The following is a description of a gene set: Genes predicted to be targets of miRBase v22 microRNA hsa-miR-1321 in miRDB v6.0 with MirTarget v4 prediction scores > 80 (high confidence targets). Human Gene Set: MIR1321 species: Homo sapiens from publication Chen Y, Wang X (PMID 31504780), and this is the list of marker genes: NISCH, SOX13, HTT, HECTD4, ZNF444, C20orf96, FZD1, LRRTM1, SH3PXD2B, GATAD2B, PIANP, TP53INP1, REG1B, SSH1, NFAM1, PAX1, LSM8, ABL2, NEMP2, NFIX, PHF8, HSD17B13, SLC2A3, ISLR, UBE2W, ANO6, NALF2, SEMA4G, AHCY, ARHGEF9, KLHDC10, PRRT2, FGF23 (NCBI Gene Id 8074), KLHL13, SLC1A3, WDTC1, RND1 (Rho family GTPase 1), PSD3, SGMS1, RASSF3, SKI, CREB3L2, SEC31A, SAMD4A, HNRNPA2B1, UBE2D3, CCDC169-SOHLH2, MYOM1, KCTD13, MEF2D, SRP54, EYA3 (EYA transcriptional coactivator and phosphatase 3), STK16, ACKR2, SDK1, RBM43, ARL6IP5, CETP, NFAT5, TRIM3, RNF103, DTX1, LASP1, IL2RG, ITGA8, SHISA7, SOX12, ABCG4, SOHLH2, CRTC2, OXCT2, DNA2, AIF1L, NSG2, ELFN2, HPCA, UBE2O, KSR2, DLK1, HOXC10, BACE2, CS, MAP3K9, IL2RB, LENG8, SNU13, AR, LSAMP, GABBR2, ZMYM3 (zinc finger MYM-type containing 3), PLAGL2, CDC42EP4, LRP2BP, METTL21A, CDHR1 (cadherin related family member 1), BAK1, ULK1, CBX6, NGF, CD300LD-AS1, KLHL9, CD44 (CD44 molecule (IN blood group)), RAB3IL1, PLXNA1, IMPDH1, NECTIN1, NAV2, WNT9B (NCBI Gene Id 7484), ADO, KDM5C, HNF4A, NDUFA10, ZFHX3, IGFBP4, AURKA, KICS2, ADGRE5, CASC3, ESRRG, BLTP3A, ATP6V0D1, OPA3, CERS2, POU2AF1, NOVA2, PCYT1A, ADAMTS4, DMBX1, TET3, ADD2, NCOR2, TBC1D24, YTHDC2, DLX3, WNT1, KLK4, HERC3, PTK2, PDLIM5, NDUFA4L2, MEIS3, JCAD